Given this list of marker genes Arf1, Krt18, Snap23, Mon2, Dnm1l, Sec24d, Atp7a (NCBI Gene Id 51824), Napa, Ica1, Scrn1, Vps4b (NCBI Gene Id 319619), Rer1, Stx12, Arcn1, Tspan8, Kif1b, Clta, Egfr, Dop1a, Uso1, Galc, Ap2b1, Ap2s1, Cog2, Ap2m1, Dst (NCBI Gene Id 98718), Ergic3, Cd63, Vps45, Atp6v1b1, Rab14, Igf2r, Sec22b, Yipf6, Clcn3, Vamp4, Ppt1, Atp6v1h, Tom1l1, Golga4, Gla, Cln5, Ap1g1, Atp1a1, Scamp3, Rab22a, Sh3gl2, Bnip3, Ctsc, Tpd52, Sgms1, Gosr2, Cope, Tmed10, Adam10, Arfgef1, Ap3s1 (adaptor-related protein complex 3, sigma 1 subunit), Arfgef2, Mapk1, Lman1 (NCBI Gene Id 70361), Scamp1, Arfip1, Rab5a, Anp32e, Rab9, Ap3b1, Tsg101, Sod1, Lamp2, Ocrl, Gbf1, M6pr, Vamp3, Arfgap3, Gnas, Napg, Stx7, Zw10, Stam, Snx2, Sec31a, Copb2, Tmx1, Pam, Stx16, Rab2a, Bet1, Abca1, Copb1, Cav2, Cltc, Ykt6, Rps6ka3, Sspn, here is a description of the gene set: species: Mus musculus from publication Howe DG, Blake JA, Bradford YM, Bult CJ, Calvi BR, Engel SR, Kadin JA, Kaufman TC, Kishore R, Laulederkind SJF, Lewis SE, Moxon SAT, Richardson JE, Smith C (PMID 30224793) Mouse genes annotated to HALLMARK_PROTEIN_SECRETION based on orthology mappings provided by the Alliance Genome Consortium Mouse Gene Set: HALLMARK_PROTEIN_SECRETION